Given this list of marker genes Rbfox2, Fzd9, Dcn (NCBI Gene Id 13179), Alb, Ppp2r3c, Gclc, Bok, Tspo, P2rx7, Abcd1, Alox12, Cck, Mllt11 (myeloid/lymphoid or mixed-lineage leukemia; translocated to, 11), Got1, Hsh2d (NCBI Gene Id 209488), Rack1, Kcnq3, Ngfr, Casp1, Kcnq2, Parp1, Atp5if1, Lrrk2, Gclm, Src, Cdkn2a, Myoc, Oga, Adcy10, Kdr, Col6a1, Ppif (peptidylprolyl isomerase F (cyclophilin F)), here is a description of the gene set: Mouse Gene Set: GOBP_MITOCHONDRIAL_DEPOLARIZATION The process in which the potential difference across the mitochondrial membrane is reduced from its steady state level. species: Mus musculus